The following is a description of a gene set: Microarray deconvolution is a technique for quantifying the relative abundance of constituent cells in a mixture based on that mixture's microarray signature and the signatures of the purified constituents. It has been applied to yeast and other systems but not to blood samples. Here we test the ability of this technique to determine the fractions of subsets of memory T cells in peripheral blood mononuclear cell (PBMC) samples. Human Gene Set: GSE11057_CD4_EFF_MEM_VS_PBMC_UP Genes up-regulated in comparison of effector memory T cells versus peripheral blood mononuclear cells (PBMC). from publication Abbas AR, Wolslegel K, Seshasayee D, Modrusan Z, Clark HF (PMID 19568420) species: Homo sapiens, and this is the list of marker genes: WDR54, FBLN7, EPHA4, CASK, EPB41, LRATD2, FAM171A1, MEGF6, DGKH, CAMK2G, ZNF75D, EGLN2, NOL7, JADE1, FBXL8, SLC25A38, ITM2A, USP46, ACE, MAF, TMEM63A, CASP6, EPS8L2, FAM117A, MFHAS1, SUSD3, CFAP36, HINT1, HAPLN3, OCIAD2, OPTN, HMOX2, NPDC1, EEF1A2, PPP2R1A, ICAM2, ATG9B, NECTIN3, TRBC1, TLE5, STOML2, MAST4, ADSL, LSR, LANCL1, GTSF1, ANKH, SLC9A3-OT1, MB21D2, ZNF862, MAP3K14, MORC4, GATA3, LINC00910, SFXN2, TMEM116, IL10RA, PAG1, BDH1, SLAMF1, NFRKB, THUMPD1, UNC5CL, IL23A, ATP8B2, PEX16, MTHFD1L, ST3GAL1, GPR171, DYRK2, MRPL41, PHF1 (NCBI Gene Id 5252), NIPAL3, SIGIRR, BAG3, PNMA1, CHMP7, TMEM200A, ITPR3, RPUSD2, EDEM1, SEPTIN1, MLLT3, SMYD2, AMMECR1, KLHL36, BIN1, TRPC1, TMEM185B, GALNT12, ITPKB, KIF22, SFMBT1, SNRPD2, ANKRD12, CXCR3, NOSIP, RABEPK, DOCK9, SLC35F2, CD5 (NCBI Gene Id 921), CNST, TTC39C, CD3D, ANO9, TRAF2, ATIC, CD96, ATP1A1, ZNFX1 (NCBI Gene Id 57169), SVIP, TBL1XR1, ARHGEF5, ACAT2, CEP85L, ESYT1, PTGER2, FXYD5, BICDL1, NUDCD3, SEC11C, CD59, RGCC, LYSMD4 (NCBI Gene Id 145748), MLF1, PIM1, STAT5B, CCDC57, CCDC107, PBX4, PRMT7, SEC22C, AFDN, DBP (NCBI Gene Id 1628), PHTF2, SLC39A8, MALT1, ARID4B, NSUN5P1, CCDC85C, APRT, CBX7, ZNF223, URI1, DNAJC19, PBXIP1, RUNX1 (RUNX family transcription factor 1), RUVBL1, XPC, NAE1, FAAH2, CAB39, CYB561D1, PRIM1, CD2, ATXN7L1 (NCBI Gene Id 57485), PLCD1, EVL, TMEM143, ST8SIA1, RNF126, RNF157, TRAT1, ALDH6A1, CD6, ECHDC2, HECA, RASGRP1, GSTK1 (NCBI Gene Id 51064), RFESD, PINX1, RPS6KA5, STMN3, RPSA, LRIG1, SNHG1, PCNX2, LIN52, PHACTR2, WWP1, FLT3LG, GOLGA7B, CCND2, DANCR, C3orf18, RPAP2, GON4L, EML4 (EMAP like 4), SLC39A13 (NCBI Gene Id 91252), NMT2, PELP1, ITK, LDOC1, RASGRF2, DNAJB1, LIME1, ANK3, PLCG1, TAF9B